The following is a description of a gene set: studied in species Homo sapiens Human Gene Set: GOBP_NEURON_MIGRATION The characteristic movement of an immature neuron from germinal zones to specific positions where they will reside as they mature., and this is the list of marker genes: ASCL1, POU4F1, NKX2-1, NRP1, TBC1D24, NTNG1, MDK, CDKL5, CCR4, KIRREL3, ULK4, BBS1, ROBO3, UNK, ABI2, ZNF609, ARHGEF2, CDK5, AXL, VRK1, NEXMIF, PTK2B, DRD1, TUBGCP2, KIF20B, PCM1, ADGRL3, ITGA3, SPOCK1, DAB2IP, GATA3, CNTN2, ADGRG1, CELSR1, WDR62, NR2F2, CHL1, FILIP1, GPR173, PSEN1, ARX, CCKAR, CXCL12, FKRP, FLNA, PAFAH1B1, FBXO45, KIAA0319L (KIAA0319 like), PEX7, NR4A2, LARGE1, PITX2, NAV1, ASPM (NCBI Gene Id 93990), CELSR2, CRKL, TYRO3, CUL5, WASF2, SDCCAG8, NRG3, NDE1, BBS4, FGF13, GNRH1, LRP12, ADAM17, ATOH1, CDK5R1, NRP2, NDEL1, SOCS7, SEPTIN14, MATN2, UNC5C, EMX2, RAC1, SHTN1, SOX1, DCX, NDNF, PHACTR1, SRGAP2C, MEF2C, GFRA3, CRK, CAMK2A, NSMF, SEMA3E, COL3A1, FAT3, CDK5R2, ELP3, VEGFA, NKX6-1, TLX3, NTNG2, DISC1, LRIG2, MDGA1, TOP2B, MARK1, RAPGEF2, PEX5, SCRT1, PLXNA1, NIPBL, USP9X, DDIT4, BARHL1, MYH10, KIAA0319, DNAAF4, PHOX2B, CEP85L, ASTN1, EVX1, FLRT2, DRGX, DCC, RELN, FZD3 (frizzled class receptor 3), SRGAP2, TUBA1A, IGSF10, DAB1, ZMIZ1, PRKG1, ABI3 (ABI family member 3), NTRK3, SCRT2, ASTN2, OLIG3, AUTS2, GAS6, DRD2, SEPTIN4 (septin 4), RHOA, FGFR1, TBX20, MARK2, PLXNA3, PLAA, SATB2, RNF7, SEMA6A, NTRK2, FEZF1, TUBB2A, SOX14, POMGNT2 (NCBI Gene Id 84892), SEMA3A, STAT3, TWIST1 (NCBI Gene Id 7967), NRCAM, VAX1, TRIM46, UNC5D, APBB2 (NCBI Gene Id 323), TNN, FOXG1, HSP90AA1, NEO1, SH3RF1, PAX6, NEUROD4, CAMK2B, YWHAE, CTNNA2, CTNNB1, NDN, MAP1B, LHX1, GPM6A, ABI1, BARHL2, LHX6, KIF26A, ALKBH1, FYN, PLXNB2, DNER, GATA2, FEZF2, TUBB2B, DCDC2, FBXO41, ACAP3, BAX, ERBB4, PEX13, CCK, SRF, NTN1, CX3CL1 (C-X3-C motif chemokine ligand 1), EOMES